Given this list of marker genes DLD, ATP5F1B, BCKDHB, PPM1K, BCAT2, here is a description of the gene set: studied in species Homo sapiens An increased concentration of isoleucine in the blood. Human Gene Set: HP_HYPERISOLEUCINEMIA Hyperisoleucinemia